Given this list of marker genes Ankfy1, Zc3h18, Pramel20, Dicer1, Wnt2, Tecrl, Nbeal1, Rd3 (retinal degeneration 3), Prdm12, Fnbp4, Arhgef12, Ssbp3, H2-D1, Ugt1a7c, Gm13043 (NCBI Gene Id 545693), Defb4, B4galt4, Abhd8, Cdc7, Trhde, Sox14 (SRY (sex determining region Y)-box 14), Tmem266, Kcnb1, Plce1, Nphp1, Cacna2d1, Erbb4, Tbx20, Ebf1, Clca2, Vapa, Arhgef33, Tc2n, Psg29, Zfp953, Cobll1, Pnrc1, Ro60, Cxcl12, Esrrg, Ptbp3, Slc35d3, Fndc4, Iqsec1, Ppargc1a, Tshz3, Mpc1, Cnot4, Gabra6, Ptpn22, Mdga2, Grm8, Map3k12, Cyp2c50, Sox5, Ugt1a6a, Sik3, Dgkb, Meis3, Kitl (NCBI Gene Id 17311), Accs, Tmem33, Degs1, Rab27b, Camta1, Trps1, Cdyl2, Rbm41, Cadm1, Magix, Celf2, Lactb2, Trib2, Trim8, Pi15, Rgs14, Chst8, Tmeff1, Cyp2c37, Adcyap1, Plcxd2, Mettl17, Atp11c, Kif7, Mat2b, Mmrn1, Eya1, Trpc5os, Gnal, Ahctf1, Clec1a, Cdca7, Rora, Chic1, Hsh2d, Ing2, Fgfrl1, Pcyox1 (prenylcysteine oxidase 1), Ugt1a9, Esrp1, Coro2a, Zfp882, Klf12, Ttn, Atn1, Dlgap1, Tex38, G6pc1, Ap3b1, Mab21l2, Tbx5, Ank3, Zfp703, Shank3, Ugt1a1, Pcdhb19, Pate9, Mtcl2, Mmp16, Lgi2, Dclk3, Rfx3, Spag9, Neurog2, Elavl4, Brd8, Ereg, Neurod1, Hgf, Rrp1b, 5730455P16Rik (RIKEN cDNA 5730455P16 gene), Csde1, Gabrb2, Golga2, Tceal8, Cyp2c54, Baiap2l1, Slc7a2, Zfp663, Dll4, Bicd1, Steap2, Rnf138, Smim10l1, Rabl3, Hacd1, Prr18, Dnajb11, Col10a1, Nfxl1, Ttc9c, Gm13040 (predicted gene 13040), Abcg5, Acadl, Acot10, Efcab2, Ttyh1, Trim30a, Plscr1, Loxl4, Kpna4, Rnf5, Rab27a, Rtn4rl1, Trio, Arid1a, Cep97, Myb, Mog (myelin oligodendrocyte glycoprotein), Tafa2, Hoxb5, Fryl, Mblac2, Tmcc3, Mrpl51, Sp7, Dbndd2, Hectd2, Vma21, Samd8, Mia2, Mgat3, Phlpp1, Pcdh7, Rev3l, Gcm2, Stk24, Akap6, Susd6, Tdrd3, Sft2d2, Ptpn12, Dcun1d1, Elmod2, Nfat5, Cd247, Tmx3, Aff1, Grm5, Bicd2, Ugt1a10, Scn8a, Dlk1, Napg, Foxp1, Fgf1, Gucy1a2, Scfd2, Myom2, Hpn, AI182371 (NCBI Gene Id 98870), Grik1, Peli2, Cdk19, Csf1, Pcdh17, Zbtb18, Man1a (NCBI Gene Id 17155), Zbtb21, Inpp5d, Stk39, Pgap2, Cdh9, Jarid2, Colec12, Abca5, Ccnc, Mex3c, Gabra1, Pde7b, Bcl7a (NCBI Gene Id 77045), Trip6, Kras, Tlcd4, Rfx4, Spint3, Ugt1a5, Lrrc3b, Kif14, Rab3c, Gm13057, Rgs3, Eya4 (EYA transcriptional coactivator and phosphatase 4), Dcaf10, Zdhhc6, Erap1, Col11a1, Sema6a, Hoxc8, Sema3d, Fgd4, Ube3c, Map3k2, Otop1, Mboat1 (NCBI Gene Id 77678), Nkiras1, Adgrb3, Wnt3, Slc35a3, Nefl, Ccnh, Srpk2, St6galnac4, Tbl1xr1, Zbtb47, Car5b, Rccd1, Adam34, Fst, 4931406C07Rik, Car3, Gask1b, Antxr1, Hoxb6, Eif4a2, Hspa4l, Rap2c, Lpp, Shh, Nxpe2, Senp8, Ikzf2, Cask, Aasdhppt, Hmgcr, Adamts5, Tbx22, Rsbn1, Tsc22d4, Fem1b, Traf3, Ogt, Grin2b, Acvr2b, Kcnk6, Armcx3, Myef2, Itgb3bp, Dimt1, Acsm2, Prex2, Azin1, Lin9, Ppp1r10, Rflnb, Nova1 (NCBI Gene Id 664883), Pop4, Mrps33, Flt4, Stc1, Kat2b, Slc9a6, Miga1, Tns2, Fut9, Kcnv1, Ugcg, Ugt1a2, Capn5, Hoxb2, Fgf10, Slc24a2, Hprt1, F2rl2, Vwc2l, Ltk, Gpbp1, Fgf7, Pnpt1, Neurod2, Galnt13, Gabra5, Hecw2, Naaladl2, A830018L16Rik, Cd2ap (CD2-associated protein), Adam28, Gpr174, Ppfia2, Samsn1, Chd1l, Mpp7, Ids, Spast, Fam168a, Dennd1b, Chd1, Edil3, Chuk, Pclo, Slit2, Gata3, Trpc5, Ednra, Setbp1, Brip1, Hmgxb4, Ctnnbl1 (catenin, beta like 1), Bltp3b, Zfp935, Rab11fip2, Rinl, Ugt1a6b, Rasl10b, Bach1, here is a description of the gene set: species: Mus musculus Genes predicted to be targets of miRBase v22 microRNA mmu_miR_126a_5p in miRDB v6.0 with MirTarget v4 prediction scores > 80 (high confidence targets). Mouse Gene Set: MIR_126A_5P from publication Chen Y, Wang X (PMID 31504780)